Given this list of marker genes Oxct2a, Acss3, Aacs, Oxct2b, Oxct1, Hmgcll1, Bdh2, Bdh1, here is a description of the gene set: This event has been computationally inferred from an event that has been demonstrated in another species.<p>The inference is based on the homology mapping from PANTHER. Briefly, reactions for which all involved PhysicalEntities (in input, output and catalyst) have a mapped orthologue/paralogue (for complexes at least 75% of components must have a mapping) are inferred to the other species. species: Mus musculus electronically inferred by orthology from the curated human pathway part of: Metabolism of lipids Reactome Pathway: Ketone body metabolism